Given this list of marker genes Agmat, Aadat, Apc, P4hb (prolyl 4-hydroxylase, beta polypeptide), Nags, Mtr, Qprt, Ddah1, Adss1, Mthfd2l, Ftcd, Gls2, Agxt, Tdh, Csad, Apip, Ass1, Slc38a8, Afmid, Acmsd, Tat, Kyat3, Egln2, Sdsl, Mtrr (5-methyltetrahydrofolate-homocysteine methyltransferase reductase), Ido2, Asl, Haao (3-hydroxyanthranilate 3,4-dioxygenase), Agxt2, Ahcyl, Nr1h4, Gstz1, Park7, Amdhd1, Bloc1s6, Pcbd1 (NCBI Gene Id 13180), Cdo1 (cysteine dioxygenase 1, cytosolic), Hal, Ggt1, Gcat, Ldc1 (NCBI Gene Id 332942), Gpt, Gcdh, Psph, Thnsl2, Prdx4, Aldh18a1, Kmo, Il4i1 (interleukin 4 induced 1), Adi1, Otc, Azin2, Mthfd1, Tha1, Ero1a, Pfas, Odc1, Gnmt, Nos1, Atp2b4, Cps1, Ttc36, Nadsyn1, Got1l1, Gfpt2, Fah, Ido1, Dao, P4ha2, Gclm, Aspa, Aldh4a1, Arg2, Nit2, Bcat1, Sds, Pcmt1, Gls (NCBI Gene Id 98298), Aldh8a1, Crtap, Nmnat2 (NCBI Gene Id 98444), Bhmt1b, Qdpr (quinoid dihydropteridine reductase), Gad1, Plod2, Tdo2, Auh, Cad, Shmt1, Mthfsl, Nos2, Asns, Pycr3, Hdc, Glul, Ucp2, Kynu (kynureninase), Hpd, Ivd, Ppat (NCBI Gene Id 97242), Cbs, Ddo, Ahcy (S-adenosylhomocysteine hydrolase), Hmgcll1, Arg1, Mthfr, Oat, Adhfe1, Mtap, Aass, Asnsd1, Prodh2, Spr, Th, Gpt2, Shmt2, Sirt4, Pcbd2, Bhmt2, Slc45a2, Kyat1, Dglucy, Psat1, Dct, Atf4, Asrgl1, Tyrp1, Cln3, Aspg, Icmt, Slc25a12, Noxred1, Ilvbl, Phgdh (3-phosphoglycerate dehydrogenase), Dlst, Slc7a11, Aasdhppt, Hgd, Oca2, P4ha1, Atcay, Nos3, Prodh, Iyd, Mecp2, Mccc1, Enoph1, Srr, Lgsn, Thap4, Nat8l, Slc38a1, Pycr1, Got2, Azin1, Glud1, Ero1b, Bckdk, Atp7a, Gamt, Mccc2 (methylcrotonoyl-Coenzyme A carboxylase 2 (beta)), Gad2, Adss2, Ndp, Pah, Uroc1, Pycr2, Plod3 (procollagen-lysine, 2-oxoglutarate 5-dioxygenase 3), Pipox, Hmgcl, Got1, Bhmt, Pemt, Gclc, Aldh5a1, Fpgs, Mri1, Bcat2, Mat1a, here is a description of the gene set: studied in species Mus musculus Mouse Gene Set: GOBP_L_AMINO_ACID_METABOLIC_PROCESS The chemical reactions and pathways involving an L-amino acid.